Given this list of marker genes CH25H, PARD6G, GNG12-AS1, GLRA4, TSPEAR, LINC01182, LINC01116, LINC02701, PHF24, HOXD10, P4HA3, LINC02147, LRCOL1, STAB2, SLC30A3, GGT5, LINC00636, SLC27A3, CASP12, TM4SF18-AS1, CTHRC1, ADAMTS4, HOXD4, ABCA4, ENSG00000212594, ENSG00000250626, LINC03122, KCNIP1, NETO1, PPFIBP1, ZNF24TR, POU4F1, RELN, SLC5A1, LRRN4CL, GPR182, ADD3-AS1 (ADD3 antisense RNA 1), NFIA-AS2, LINC01748, CYP2AC1P, UNC5A, LOX, KLHL4, PTX3, LINC02653, KRT222, PRR5L (NCBI Gene Id 79899), MSMP, ACSM2B, HOXD9, CMKLR2, C6orf141, LRRC70, NRP2, LETR1, LINC02840, LINC02058, HOXD3, NTS, GJC2, RAB11FIP5, LRRC15, FOXC2, FZD10, GJD3, HAPLN3, LINC02668, GALNT15, PLIN5, FLT4, ZP2, CCL21, HOXD-AS2, DAND5, here is a description of the gene set: from publication Cao J, O'Day DR, Pliner HA, Kingsley PD, Deng M, Daza RM, Zager MA, Aldinger KA, Blecher-Gonen R, Zhang F, Spielmann M, Palis J, Doherty D, Steemers FJ, Glass IA, Trapnell C, Shendure J (PMID 33184181) Marker genes curated from the annotated cluster as represented in the Descartes Human Gene Expression During Development database. studied in species Homo sapiens The gene expression program underlying the specification of human cell types is of fundamental interest. The study authors generated human cell atlases of gene expression and chromatin accessibility in fetal tissues. For gene expression, the study authors applied three-level combinatorial indexing to >110 samples representing 15 organs, ultimately profiling ~4 million single cells. The study authors leveraged the literature and other atlases to identify and annotate hundreds of cell types and subtypes, both within and across tissues. Our analyses focused on organ-specific specializations of broadly distributed cell types (such as blood, endothelial, and epithelial), sites of fetal erythropoiesis (which notably included the adrenal gland), and integration with mouse developmental atlases (such as conserved specification of blood cells). These data represent a rich resource for the exploration of in vivo human gene expression in diverse tissues and cell types. Human Gene Set: DESCARTES_FETAL_LUNG_LYMPHATIC_ENDOTHELIAL_CELLS